The following is a description of a gene set: species: Homo sapiens Abnormal sex determination Anomaly of primary or secondary sexual development or characteristics. Human Gene Set: HP_ABNORMAL_SEX_DETERMINATION, and this is the list of marker genes: CBX2, NR0B1, ZFPM2, VAMP7, CYB5A, CILK1, WWOX, DHH, MAP3K1, GATA4, WNT4, SRY, DHX37, RSPO1, NR5A1, AKR1C4, AKR1C2, CYP17A1, SOX9, CYP11A1, WT1